Given this list of marker genes MECOM, HDLBP, TMEM79, GJC1, TRPV6, OSR2, ABI1, CDC14A, LRRTM4, ERRFI1, KRT222, BCL11A, CYP2W1, ADAMTS5, HIVEP3, ZBTB22, PLAG1, NRGN, TBCC (NCBI Gene Id 6903), PEX5L, EPHA1, ZNF462, SLC8B1, FIBIN, NLGN2, DSCAM, ELAVL2, ATOH8, GDAP1L1 (ganglioside induced differentiation associated protein 1 like 1), SMG5, ADRB3, TMEM126B, PELI2, DLG3, KLC4, DAB2IP (DAB2 interacting protein), PLXDC2, IRAG1, DGLUCY, CLN3, KCNN2, DPF3, KLHL25, PRDM1, INPPL1, MSI2, SSBP3 (NCBI Gene Id 55126), ONECUT2, PHOX2B, SOWAHA, SLC39A5, GIMAP1, TFIP11, MFRP (membrane frizzled-related protein), KTN1, NR3C2, AICDA, IVNS1ABP, ITGA3, NEUROD6, POLR1G, FXYD3, OTUB2, PUS7L, CERCAM, PLP1, PMP22, CDK15, PRPH, PDPN, QRICH1, MRPL2, LIN28A, TXNDC12, HTN1, MEF2D, NRP2, STAG3, LIG3, TUG1, IRAK4, BTBD3, MB21D2, LDB2, GPR158, BRPF1, PTMA, JPH4, here is a description of the gene set: Genes having at least one occurrence of the highly conserved motif M82 CTGYNNCTYTAA in the regions spanning 4 kb centered on their transcription starting sites. The motif does not match any known transcription factor binding site. from publication Xie X, Lu J, Kulbokas EJ, Golub TR, Mootha V, Lindblad-Toh K, Lander ES, Kellis M (PMID 15735639) Comprehensive identification of all functional elements encoded in the human genome is a fundamental need in biomedical research. Here, we present a comparative analysis of the human, mouse, rat and dog genomes to create a systematic catalogue of common regulatory motifs in promoters and 3' untranslated regions (3' UTRs). The promoter analysis yields 174 candidate motifs, including most previously known transcription-factor binding sites and 105 new motifs. The 3'-UTR analysis yields 106 motifs likely to be involved in post-transcriptional regulation. Nearly one-half are associated with microRNAs (miRNAs), leading to the discovery of many new miRNA genes and their likely target genes. Our results suggest that previous estimates of the number of human miRNA genes were low, and that miRNAs regulate at least 20% of human genes. The overall results provide a systematic view of gene regulation in the human, which will be refined as additional mammalian genomes become available. Human Gene Set: CTGYNNCTYTAA_UNKNOWN species: Homo sapiens